The following is a description of a gene set: from publication Chen Y, Wang X (PMID 31504780) Mouse Gene Set: MIR_1249_5P Genes predicted to be targets of miRBase v22 microRNA mmu_miR_1249_5p in miRDB v6.0 with MirTarget v4 prediction scores > 80 (high confidence targets). studied in species Mus musculus, and this is the list of marker genes: Grhl2, Fgf12 (fibroblast growth factor 12), Trim29, Dcx, Psg21, Hnf4a, Psg22, Eya3, Trp53inp2, Rasal2, Grk3, Arf3, Tomt, Psg19, Sprr2f, Tapbp (NCBI Gene Id 28066), Lpar2, Wdr26, Nova2, Ccdc85a, Syp, Dennd5b, Rab11fip5, Syt1, Pomk, Heatr5a, Srcin1, Gas1 (NCBI Gene Id 14451), Gpr75, Cfl1, Cldn19, Scn8a, Lypd5, Phyhip, Hoxc10, Prcp, Ttc9b, Sash1, Sprr2h, Galnt17, Pard3b, Thpo, Fign, Foxp4, Mtcl2, Ptpro, Tnni1, Fndc9, Erc1, C1qtnf1, Nhsl2, Csnk1g1, Impdh1, Lrrc8a, Acin1, Mef2d, Sprr2e, Mapk10, Tektl1, Erv3, Lrp4, Lrrc56, Dpy19l3 (dpy-19 like C-mannosyltransferase 3), Tedc1, Gnat1, Ptpn3, Mrpl44, Tcf20, Abcg4, Hgf, Agap1, Psmf1, S100a16, Zdhhc9, Cdc27, Crmp1, Pitpnm3, Rapgef1, N4bp1, Psg27, Tdrd3, Sfrp1, 2610528J11Rik, Cuedc1, Rdh12, Zfp395, Fjx1, Rbfox2, Ift80, Hoxd13, Zmiz1, Pabpc1l, Prrg3, Frs2, Acap3, Cox10, Arhgdib, Adar, Prrc2b (NCBI Gene Id 98867), Smarcc1, Zic4, Nav2, Thbd, Dnajc27 (DnaJ heat shock protein family (Hsp40) member C27), Ubqln2, Zfp703, Faim2, Drgx, Ap1s1, Dnaaf9, Prss34, Atf7, Lasp1, Leng8, Nfat5, Pcgf2, Ctps2, Ccbe1, Zfp92, Igtp, St3gal1, Cntn2, Phlpp2, Stox2, Cyyr1, Sox12, Eif4e1b, Hebp2, Ctsb, Nfix, Parvg, Sit1, Psg25, Bach2, Trim14, Col5a1, Pla2g4e, Anxa5 (NCBI Gene Id 97115), Slc22a23, Git1, Aak1, C5ar1, Plxna4, Diaph2, Gle1, Stmn1, Arfip1, Hsd17b6, Zfp169, Pacs1, Creb3l1, Apba1, Zfp36l1, AU040320, Vangl1, Kcnj4, Adra1a, Shisa7, Htt, Nptxr, Tenm4, Cbx2, Fxr2, Rbm14, Dlg3 (discs large MAGUK scaffold protein 3), Foxj2, Pla2g5, Cd2bp2, Tnfsf18, Ppil3, Rnf152, Atp6v0d1, Kalrn, Plekho2, Ankrd61, Slc24a2, Iqsec2, Fam167a, Upk1a, Kazn, Zscan29, Wdtc1, Lrrc1, Kif14, Coro2b